The following is a description of a gene set: Abnormality of the thenar eminence Human Gene Set: HP_ABNORMALITY_OF_THE_THENAR_EMINENCE An abnormality of the thenar eminence, i.e., of the muscle on the palm of the human hand just beneath the thumb. studied in species Homo sapiens, and this is the list of marker genes: FGFR2, RPL9, EIF4A3, RPL27, ADA2, HEATR3, RPS19, RPS27, RPL35A, RPS15A (NCBI Gene Id 6210), RPL26, HOXA13, RPL31, SALL4, TBX5, RPL8, RPL35, RPS17, RPS28, FBXW11, TSR2, RPS7, RPL11, EMILIN1, GATA1, RPS26, RPL5, RPS29 (NCBI Gene Id 6235), RPL15, FGD4, RPL18, RPS24, RPS10, RPS20, RAD51C